The following is a description of a gene set: species: Mus musculus Mouse Gene Set: EHMT2_TARGET_GENES Genes containing one or more binding sites for (Ehmt2) in their promoter regions (TSS -1000,+100 bp) as identified by GTRD version 20.06 ChIP-seq harmonization. from publication Yevshin I, Sharipov R, Kolmykov S, Kondrakhin Y, Kolpakov F (PMID 30445619), and this is the list of marker genes: Mff, Mir142hg, Mkrn3, Sox30, Mapk8ip2, Selenot, Cacng2, Redic1, Grid2ip, Scrt1, Cntnap2, Palld, Neurod4, Kdm3a, Slc38a8, Xkr6, Cyb5r4, Ndufs5, Slc39a3, Dnah10, Barhl1, Vgf, Omg, Nr3c1, Gm25336, Glra1